The following is a description of a gene set: studied in species Homo sapiens Catalysis of the conversion of retinoic acid to 4-hydroxy-retinoic acid. Human Gene Set: GOMF_RETINOIC_ACID_4_HYDROXYLASE_ACTIVITY, and this is the list of marker genes: CYP2W1, CYP26B1, CYP2C8, CYP26A1, CYP3A7, CYP2S1, CYP2C18, CYP3A5, CYP3A4, CYP26C1 (NCBI Gene Id 340665)